Given this list of marker genes H4C9, CCNA2, H4C14, RFC3, MRE11, H4C12, RAD9B, H2BC12L, H2BC15, ATRIP, ATM (NCBI Gene Id 8068), H2BC5, H4C15 (H4 clustered histone 15), SIRT6, H2BC26, PPP4R2, RNF4, RFC5, TP53BP1, SUMO2, H2BC10, UBA52, H4C2, RPA3, CHEK1, UBB, H4C11, BABAM2, HERC2, RFC4 (replication factor C subunit 4), UIMC1, RFC2, RAD9A, RMI1, H2BC12, CLSPN, BLM, BABAM1, CDK2, BARD1, H2BC6, H2BC11, HUS1, TIPIN, H4C16, RBBP8, RMI2, BRCC3, RPS27A, RPA2, DNA2, TOPBP1, RPA1, H4C8, BRCA1, H2BC17, H2BC4, RAD1 (RAD1 checkpoint DNA exonuclease), H2BC21, H4C3, EXO1, TOP3A, BRIP1, H4C6, WRN, H2BC1, H2BC9, H3-4, CCNA1, RHNO1, H2BC14, H4C5, MDC1, RNF8, UBE2N, UBE2I, UBE2V2, KAT5, RAD50, H2AX, RNF168, PPP4C, RAD17, H4C4, H2BC8, NSD2, PIAS4, H2BC3, H2BC13 (NCBI Gene Id 8340), UBC, H4C13, ABRAXAS1, H2BC7, NBN, ATR, TIMELESS, H4C1, here is a description of the gene set: Human Gene Set: REACTOME_PROCESSING_OF_DNA_DOUBLE_STRAND_BREAK_ENDS Processing of DNA double-strand break ends species: Homo sapiens